The following is a description of a gene set: Human Gene Set: GSE3337_CTRL_VS_4H_IFNG_IN_CD8POS_DC_DN Genes down-regulated in comparison of untreated CD8+ dendritic cells (DC) at 4 h versus those treated with IFNG at 4 h. Although much is known on the transcriptional profiles of dendritic cells (DCs) during maturation, the molecular switches critical for the acquisition of a tolerogenic program by DCs are still obscure. In the present study, we explored the gene expression pattern of CD8+ DCs purified from the mouse spleen and treated with interferon (IFN)-gamma. The cytokine, indeed, potentiates the tolerogenic potential of this DC subset via induction of the immunosuppressive tryptophan catabolism mediated by indoleamine 2,3-dioxygenase (IDO). By comparing the expression of the IFN-gamma-modulated genes in IDO+ versus IDO- murine DCs, we found a consistent and selective association of the IDO-competent phenotype with the down-modulation of the Tyrobp gene, encoding the adapter molecule DAP12. IFN-gamma-mediated down-modulation of this gene involved IFN consensus sequence binding protein (ICSBP), a transcription factor also known as IRF-8. While silencing of Tyrobp conferred IDO functional competence on IDO- DCs, silencing of Icsbp1 in IDO+ cells completely abolished IDO expression and function. In parallel, silencing of TYROBP conferred IDO competence on human IDO- DCs while silencing of IRF8 impaired IDO expression and activity in human IDO+ DCs. Therefore, the same small set of molecular switches controls IDO competence in murine and human DCs. studied in species Homo sapiens from publication Orabona C, Puccetti P, Vacca C, Bicciato S, Luchini A, Fallarino F, Bianchi R, Velardi E, Perruccio K, Velardi A, Bronte V, Fioretti MC, Grohmann U (PMID 16339401), and this is the list of marker genes: GPR132, RAB7A, RPL3, TCF19, GSPT1, ELAVL2, IER3, XCL1, TAP1, SCAF11, ENPP1, UBD, CTSC, GZMB, EIF1AY, NONO, STAT1, IMP4, PRRX1, PKIB, IKBKB, BZW2, CDK4, JUN, NDRG1, GIMAP1, LYPLA1, RNF14, PLG (NCBI Gene Id 90749), PML, SWAP70, SNAPC3, TXK, TNS2, ABR, IFIT3 (NCBI Gene Id 8376), ARFGEF1, PPAT, CXCL10, GIMAP4 (NCBI Gene Id 55303), NCK2, NOTCH4, KDR, TRAF3IP2, H2BC5, GBP7, CASP4, NOC4L, TNF, CSNK1D, FBL, RBMXL1, CAMK2D, SP4, NMBR, VPS54, ST6GALNAC6, UGGT1, LMAN2, MXD1, PCGF5, HERC2, RBL1, GTPBP2, ARHGEF2, GLIPR2, CPNE3, ADGRA3, PNPO, IFI35, CD44, ARHGAP5, PREP, KLF4, CD8B, LIMA1, IFIT2, PABPC1, AHRR, ALB, ATP5PO, TNFAIP2, PSMB9, SLA, RORA (NCBI Gene Id 6095), DR1, KHDC1L, ARF3, ST3GAL6, HOPX, GBP2, TOR3A, GPD2, IDNK, NOP10, MTMR1, STX2, RMDN3, USP18, LXN, CCDC88A, ZNFX1, LMNB1, STOML2, SMAGP, ZNF106, TG, CAP1, CA5A, PHETA1, FAU, CD2BP2, PSMB10, ATP5F1A, SOCS1, STAT3, CHIA, TLR7, PAPOLA, CD40, DAXX, NAMPT, STX3, CDC73, ACADL, GRAMD2B, WARS1, USP22 (NCBI Gene Id 79397), ICOS, KSR1 (kinase suppressor of ras 1), CAND1 (cullin associated and neddylation dissociated 1), GADD45G, SLFN12L, APLP1, IL13RA2, DCPS, LANCL2, HSD3B7, PRKCH, GGPS1 (geranylgeranyl diphosphate synthase 1), TNFAIP3, AP1S1, CLK2, TIMM8A, ABCC1, IL18RAP, NXF1, NDUFA6, GBP4, SERPINA10, TXNDC17, TUBB, PPP3CB, IL18, LTBP2 (NCBI Gene Id 83981), PDIA6, GNB4, CNN3, MPEG1, MDM1, CCNE2, TPSB2, YKT6, TRIM21, CX3CR1, TNNC2, MRPL54, CEBPG, MED28, POU6F1, KRT84, CSF1, ENTPD1 (NCBI Gene Id 953), PRDM1, IRF1, FLI1, UBA7, STAM2, PFKP, HNRNPAB, LAT, GPN2, TPST1, UPP1, NBN, IFIT1B, CD36, PON1, SNRPD3, MYC, FLNB, SERPINB1, GABRD, ESD, CHPT1, CCL1, FGL2, ADAR, ANXA2, PSMB8